The following is a description of a gene set: species: Mus musculus Peptide hormone biosynthesis Mouse Gene Set: REACTOME_PEPTIDE_HORMONE_BIOSYNTHESIS, and this is the list of marker genes: Fshb, Inhba, Inhbc, Pcsk1, Inhbb, Lhb, Cga, Inhbe, Inha, Tshb (thyroid stimulating hormone, beta subunit), Pomc